The following is a description of a gene set: Genes predicted to be targets of miRBase v22 microRNA hsa-miR-1180-5p in miRDB v6.0 with MirTarget v4 prediction scores > 80 (high confidence targets). species: Homo sapiens Human Gene Set: MIR1180_5P from publication Chen Y, Wang X (PMID 31504780), and this is the list of marker genes: DNAJB1, AMMECR1, RNF38, SEMA3C, ZC3H12D, PHC3, SPOPL, MMP16, DCAF10 (NCBI Gene Id 80211), TMEM121B, PDXDC1, PDE11A, TEAD3, HSPB7, SPSB1, ZNF641, MIA2, TXLNA, HEXIM1, IQGAP3 (IQ motif containing GTPase activating protein 3), TUBAL3, RCAN2, BET1L, FAM170B, CCNE1, CASQ1, MARCHF9, RBFOX1, SHPK, EPCIP, LRRC8A, ITPRIPL2, SCUBE3, SNU13, ZNF850, TM9SF3, CCP110 (NCBI Gene Id 9738), EPM2A